The following is a description of a gene set: Mutation-caused aberrant Abeta to crosstalk between extrinsic and intrinsic apoptotic pathways. Pathway ID: N01005. Pathway type: Variant. Pathway class: nt06460 Alzheimer disease. Human Gene Set: KEGG_MEDICUS_VARIANT_MUTATION_CAUSED_ABERRANT_ABETA_TO_CROSSTALK_BETWEEN_EXTRINSIC_AND_INTRINSIC_APOPTOTIC_PATHWAYS Pathway Definition from KEGG: APP* -> Abeta -> FAS -> FADD -> CASP8 -> BID -> (BAX,BAK1) -> CYCS == APAF1 -> CASP9 -> CASP3 species: Homo sapiens, and this is the list of marker genes: BID, CASP3, CASP8, CASP9, FADD, BAX (BCL2 associated X, apoptosis regulator), APP, APAF1, BAK1, FAS, CYCS